The following is a description of a gene set: Human Gene Set: REACTOME_SIGNAL_ATTENUATION species: Homo sapiens Signal attenuation, and this is the list of marker genes: IRS2, MAPK3, MAPK1, SHC1, SOS1, GRB2, INS, INSR, GRB10, IRS1